The following is a description of a gene set: A process that prevents non-homologous end joining at telomere, thereby ensuring that telomeres do not fuse. Human Gene Set: GOBP_PROTECTION_FROM_NON_HOMOLOGOUS_END_JOINING_AT_TELOMERE species: Homo sapiens, and this is the list of marker genes: TFIP11, TERF2, XRCC1, DCLRE1B, ERCC1, TERF2IP, ERCC4, ACD, NBN